The following is a description of a gene set: species: Mus musculus Mouse Gene Set: ZKSCAN17_TARGET_GENES from publication Yevshin I, Sharipov R, Kolmykov S, Kondrakhin Y, Kolpakov F (PMID 30445619) Genes containing one or more binding sites for (Zkscan17) in their promoter regions (TSS -1000,+100 bp) as identified by GTRD version 20.06 ChIP-seq harmonization., and this is the list of marker genes: Mis18bp1, Sntb2, Echdc2, Gm12740, Gm15782